The following is a description of a gene set: Mouse genes annotated to HALLMARK_ALLOGRAFT_REJECTION based on orthology mappings provided by the Alliance Genome Consortium from publication Howe DG, Blake JA, Bradford YM, Bult CJ, Calvi BR, Engel SR, Kadin JA, Kaufman TC, Kishore R, Laulederkind SJF, Lewis SE, Moxon SAT, Richardson JE, Smith C (PMID 30224793) studied in species Mus musculus Mouse Gene Set: HALLMARK_ALLOGRAFT_REJECTION, and this is the list of marker genes: Cxcr3, Irf7, Eif3d, H2-Ob, Tap2, Cfp (complement factor properdin), Cd80, Cxcl13, Rars1, Cd40lg, Eif3a, Cd74, Bcat1, Eif5a, Icosl, Cd40, Cd8b1, Ache, Gzmb, Tpd52, Ifngr1, Il13, Il9, Jak2, Irf4, Nos2, Cd3g, Socs5, Traf2, Ccl22, Krt1, Cd1d2, Stab1, Akt1, Fgr, Spi1, Ccnd2, Ccr5, Socs1, Nck1, Pf4, Tap1, Cxcl9, Gpr65, Hdac9, Brca1, Map4k1, Eif3j1, Trat1, Cd96, Tgfb1, Ncf4, Tapbp, Tgfb2, Il2, Ifngr2, Cd2, H2-Ea, Cartpt, C2, Ifng, Ptpn6, Cd86, Psmb10, Il2ra, Flna, Il12rb1, Ly75, Icam1, Cd47, Capg, Bcl10, Ereg, Cd79a, Fasl, Rpl3l, Lif, Klrd1, Tlr6, Il11, Irf8, Ccr2 (C-C motif chemokine receptor 2), Lck, Ncr1, Npm1, Il1b, Inhba, Cd3d, Tnf, Mmp9, Dyrk3, Was, Itgb2, B2m, Mtif2, Stat4, Elane, Gzma, Rps19-ps6, Glmn, Egfr, Il4ra, Cd7, Ube2n, Gcnt1, Il2rg (NCBI Gene Id 16186), Il27ra, Fcgr2b, Il7, Hcls1, Il4, Bcl3, Abi1, Degs1, Itk, Cd247 (NCBI Gene Id 98717), Ifnar2, Lcp2, Thy1, Cd8a, Stat1, F2r, Cd3e, Tlr3, Ccl5, Igsf6, Srgn, Tlr1, Wars1, H2-DMb2, Csk, Lyn, St8sia4, Apbb1, Rps3a1, Ikbkb, Inhbb, Mrpl3, Abce1, Dars1, Zap70, Ripk2, Il12a, Acvr2a (NCBI Gene Id 11480), Galnt1, Prf1, Fas, Mbl2, Il16, Ccnd3, Tlr2, H2-Aa, Rpl9, Ccl7, Eif4g3, Ltb, Csf1, Il2rb, Il12b, Rpl39-ps, Il18, Ccr1, Nlrp3, Crtam, Aars1, Il15, Fyb1, Il6, Il10, Sit1, Map3k7, Ets1, Hif1a, Itgal, Prkcg, Cd28, Ube2d1, Nme1, Ctss, Cdkn2a, Rps9, Il18rap, Ly86, F2, Cd4, Ccl11 (C-C motif chemokine ligand 11), H2-DMa, Ptprc, Timp1, Prkcb, Elf4, H2-Oa